The following is a description of a gene set: Any process that results in a change in state or activity of a cell or an organism (in terms of movement, secretion, enzyme production, gene expression, etc.) as a result of a nicotine stimulus. species: Homo sapiens Human Gene Set: GOBP_RESPONSE_TO_NICOTINE, and this is the list of marker genes: VCAM1, CHRNB3, CHRNB2, CHRNA2, BAD, NTRK1, IL13, PPP1R9B, OPRK1, ATP1A2, CHRNA3, OPRD1, CREB1 (cAMP responsive element binding protein 1), PENK, GPX1, TACR1, MAPK1, CASP3, NFKB1, KCNK1, HDAC2, FOSB, CHRNA7, LYPD1, NKX6-1, RELA, DRD2, GNAT3 (NCBI Gene Id 399515), B2M, EDN1, CHRNA1, SLC6A3, GRM2, HMOX1, CHRNB4, AVP, CHRNA5, ABAT, CHRNA4, CHRNB1, PPARA, CHRNA6, TNF, BCL2, PDX1, MMP2, GABBR1, MT-ND4, MSX1